Given this list of marker genes SESN2, HTT, SPTLC2, ADRB2, SPTLC1, here is a description of the gene set: studied in species Homo sapiens Human Gene Set: GOBP_REGULATION_OF_LIPOPHAGY Any process that modulates the frequency, rate or extent of lipophagy.